The following is a description of a gene set: from publication Marigo I, Bosio E, Solito S, Mesa C, Fernandez A, Dolcetti L, Ugel S, Sonda N, Bicciato S, Falisi E, Calabrese F, Basso G, Zanovello P, Cozzi E, Mandruzzato S, Bronte V (PMID 20605485) Genes up-regulated in CD11b+ cells from spleen of healthy C57BL6 mice versus CD11b+ cells from tumor infiltrating monocytes of BALB/c mice bearing 4T1 mammary carcinoma. Human Gene Set: GSE21927_SPLEEN_C57BL6_VS_4T1_TUMOR_BALBC_MONOCYTES_UP Tumor growth is associated with a profound alteration of myelopoiesis, leading to recruitment of immunosuppressive cells known as myeloid-derived suppressor cells (MDSCs). Analyzing the cytokines affecting myelo-monocytic differentiation produced by various experimental tumors, we found that GM-CSF, G-CSF, and IL-6 allowed a rapid generation of MDSCs from precursors present in mouse and human bone marrow (BM). BM-MDSCs induced by GM-CSF+IL-6 possessed the highest tolerogenic activity, as revealed by the ability to impair the priming of IFN- -producing CD8+ T cells upon in vivo adoptive transfer. Moreover, adoptive transfer of syngeneic, GM-CSF+IL-6-conditioned MDSCs to diabetic mice transplanted with allogeneic pancreatic islets resulted in long term acceptance of the allograft and correction of the diabetic status. Cytokines inducing MDSCs acted on a common molecular pathway. Immunoregulatory activity of both tumor-induced and BM-derived MDSCs was entirely dependent on C/EBP transcription factor, a key component of the emergency myelopoiesis triggered by stress and inflammation. Adoptive transfer of tumor antigen-specific CD8+ T lymphocytes resulted in therapy of established tumors only in mice lacking C/EBP in myeloid compartment. These data unveil another link between inflammation and cancer and identify a novel molecular target to control tumor-induced immune suppression. We used gene expression analysis to identify those factors, secreted by tumor-infiltrating MDSC, which could drive emathopoiesis. Moreover we compare gene expression profile of tumor-induced MDSC, obtained from either the spleen and the tumor infiltrate of tumor bearing mice, and in vitro bone marrow-derived MDSC. species: Homo sapiens, and this is the list of marker genes: PCOTH, ATP5ME, GOLGA3, UBE2O, EIF2B4, SCN1B, RPS7, SMPD1 (sphingomyelin phosphodiesterase 1), PARK7, OR3A3, RPLP2, CHD9, SLC25A6, EIF3F, LTA4H, CERK, FN1, PNMA1, RPL35, GNG10, SGTA, STX1A, RPS10, RPL35A, MZT2B, MYO9B, UCKL1, HINT1, RGP1, PLA2G2E, FAM120A (NCBI Gene Id 23196), PABPC3, DDX46, MAPK14, FXR1 (NCBI Gene Id 8087), BTF3, FBXO9, LAPTM5, PWAR5, RPL3, SYNRG, FGF9, RBMS3, NUP133, RPS3, RPL29, MAP4K1, UQCRH, VAMP2, ORC2, NPLOC4, EEF1D, SPATA7, RAB4A, RPS8, PRPSAP1, FMNL1, RPL6, SYNE3, ARB2A, MED13L, DHX15, IL4R, GNAQ, UQCRB, RPS3A, GUSBP3, EEF1G, AMZ2, FDPS, ACRV1, KDM6B, ASB1, CD7 (NCBI Gene Id 924), NR1H3, RASSF2 (NCBI Gene Id 9770), EFNA1, PRDM10, KLHDC2, LPL, CBX7, AXL, ICAM3, RAB40A, RHOT2, RPS17, GUSB (NCBI Gene Id 2990), NDRG3, HCFC2, RPL13, TMEM161A, P4HTM, SPSB3 (NCBI Gene Id 90864), RPL5, SLK, SNRPD2, TPT1, VPS51, ST14, ARFGAP3, SLC7A8, HADHA, NHERF1, SRF, NOSIP, POMT1, RPS27A, TOMM20, AAMP, ARHGAP19, AURKB, NDUFB1, RPL21, NFRKB, GPAA1, LAMTOR3, TUFM, ATP5F1A, SOD3, RPL7A, DHX30, SIT1, TCF21, RPL15 (ribosomal protein L15), SIGIRR, WNT1, PRODH, IGF2R, CYTH4, ANKRD1 (NCBI Gene Id 27063), FOCAD, NMU (NCBI Gene Id 10874), ATP5MJ, C4BPA, ZC3H13, GGA1, GOLGA4, ACAA2, KCNJ6, FBL, RPL17, COX6C, RBM15, TNP1, LMTK2, USP34, GSK3B, ATP5MG, CIRBP, PTEN, PBRM1, IDUA, COX4I1, SSR2, RPS15A, NAAA, CAMLG, PFDN5, BIN2, ACTG1, STT3A (NCBI Gene Id 8071), PIK3C2B, RPL18, WDR37, NACA, SERPINB4, OR10H2, RPL7, EIF3L, UBE4B, CRYL1, EIF4B, PABPC1, TYK2, BHLHE41, SSR4, CYP27B1, PNN, ZNF821, TCP10L3, GGNBP2, VPS26A, GPD2, CMPK1, CA11, TRPC1, RPS5, EIF3H, MICAL1, CLSTN1, EEF2, RPL37, EEF1B2, XYLT1, ETHE1, RPL4, STATH, PIM1, UXT, KLF9